The following is a description of a gene set: studied in species Mus musculus Mouse Gene Set: REACTOME_DNA_REPAIR DNA Repair, and this is the list of marker genes: Nbn, H4c17, H2bc6, Brca2, Spidr, Pias1, Mre11a, Cops7b, Ube2n, H2ab2, Rbbp8, Usp7, H2bc24, H2ac18, Gtf2h3, Babam1, Rpa3, Terf1, Ercc3, Ubb, Fancb, Faap100, Mnat1, Ube2v2, Actr5, Uba52, Parp1, Sumo1, Dclre1a, Rbx1, Usp1, Nsd2, Fancc, Alkbh5, Dtl, Poll, Msh3, Dclre1b, Ung, H2bc7, Pot1a, Fan1, Ube2b, Vcp, Gtf2h1, H2ac15, Fancm, Rfc1, Rps27a, Ercc4, Poli, H2bc21, Rnf168, Pold3, Sumo2, Rnf4, Prpf19, Rpa2 (NCBI Gene Id 99984), Ercc8, Ubc (ubiquitin C), Rev1, Mlh1, Brca1, Cetn2, Isy1, Pole, Ino80, Polr2d, Rfc4, H2bc12, Pias3, Mdc1, Pold1 (polymerase (DNA directed), delta 1, catalytic subunit), Pclaf, Cenpx, Ubxn1, H2ab3, Neil1, H2ac22, Xrcc3, Ufd1, Firrm, Rad51c, Brcc3, Kat5, Ino80c, Sirt6, Usp10, Eya2, Polr2c, Polh, Rfc5, Rfc3, Bard1, Mapk8, Rif1, Abraxas1, Pcna, Eme1, Polr2k, Palb2, Dna2, Pms2, H2bc11, Chd1l, Nhej1, Faap24, Eya4, Slx1b, H4c3, Gtf2h5, Kdm4b, H2ac12, Tcea1, Topbp1, Cops2, Polr2i, Nploc4, Xrcc4, Trim25, H2ac11, Polr2e, Rad50, Herc2, Top3a, Kpna2rt, Brip1, Uimc1, Tdg, Ddb1, Neil3, Acd, Slx4, Fance, Cops3, Rhno1, Ccna2, Nthl1, Pole3, Terf2ip, Xrcc6, Trp53bp1, Fancf, H2bc23, H2bc4, Fanci, Yy1 (NCBI Gene Id 22632), H2ac10, H4c14, Pole4, Ercc5, Exo1, Ppp4r2, Polr2a, Rmi2, H2ac19, Fen1, Ube2l6, Ino80b, Lig4, Rnf8, Polr2l, Actr8, H2ac6, Xrcc5, Msh2, Zfp830 (NCBI Gene Id 66983), Nfrkb, H2bc26, Apex1, H2bc3, Polr2b, Fanca, Blm, Mad2l2, Cops5, H2bc8 (NCBI Gene Id 319181), Tfpt, Abl1, Xrcc1, Ogg1, H4c4, Bap1, H4c11, Wrn, Smug1, Cenps, Isg15, Gps1, Hus1, Pnkp, Parp2, H2aj, Cops8, Baz1b, H4c16, Kpna2, Prkdc, Chek2, H2ac4, Uba7, Fancd2, H4c1, Eya3, H4c9, Rad51b, H2bc14, Polr2f, Mpg, Wdr48, Actl6a, Lig1, Pold2, Polk, Apbb1, Actb, Ercc6 (excision repair cross-complementing rodent repair deficiency, complementation group 6), Uba52rt, Polb, Xpc, Rad17, H2ac20, H2ac13, H4c18, Polr2h, H2bc13, Cops6, Xrcc2, Cops4, Gen1, Atm, Atrip, H2az2, Mutyh, Rad23a, Rad51d, Ccna1, Gtf2h4 (general transcription factor II H, polypeptide 4), H4c6, H4c2, Msh6, Polr2g, Eya1, Parg, Rfc2, Ercc1, H4c8, Sprtn, H3f4, Timeless, Rad23b, Kdm4a, Usp45, Rchy1, Rmi1, Mbd4, Rad1, Fancg, Ppp5c, H2bc15, Tipin, Ddb2, Cops7a, Pole2, Mcrs1, Fignl1, Rad9b, Smarca5, Pias4, Neil2, Cul4b, Fancl, Ppp4c, Ube2i, Tdp1, H2bc1, Polm, Ino80d, Rpa1, Ruvbl1, H2ac24, H4c12, Poln, Pold4, Adprs, Rad9a, Terf2, H2ac7, Clspn, Xpa, Uvssa, Ube2t (ubiquitin-conjugating enzyme E2T), H2bc9, Sumo3, Ino80e, Lig3, H2ac8, H2ax, H2bc22, Usp43, Cdk7, Aqr, Mus81, Babam2, Rad51ap1, Chek1, H2ac23, Paxip1, Faap20, Tdp2 (tyrosyl-DNA phosphodiesterase 2), Ercc2, Polq, Rev3l, Rad18, Rad51 (NCBI Gene Id 99282), Xab2, Rnf111, Eme2, Gtf2h2, Rad52, H2ab1, Dclre1c, Trp53, Cdk2, Fto, Cul4a, Ccnh